Given this list of marker genes CNKSR2, TP53INP2, DLG1, RALGAPA1, SPIRE1, CLDND1, EIF4ENIF1, PKP4 (NCBI Gene Id 8502), RAN, DCUN1D4 (NCBI Gene Id 23142), UBE2H, WSB1, RABEP1 (NCBI Gene Id 9135), DNAJB14, TNS2, RABGEF1 (RAB guanine nucleotide exchange factor 1), ZNF536, ZEB2, UFSP2, POMT2, DIRAS1, ZER1, NOL6, BTBD3, GPRC5B, MGAT3, OCIAD1, MARF1, FBXO21 (NCBI Gene Id 23014), HERC2, PRXL2A, PTK2, FAM8A1, DYNC1I2, RASSF3, MEGF9, APPBP2, GLTP, CCDC88A, FNIP2, AGPAT4, ABHD6, WSB2, SLAIN1, BTRC (NCBI Gene Id 8945), STAMBP, PLEKHB1, MOAP1, EPB41L3, ABI2, NCS1, KIDINS220, NGRN, CCDC82, TJAP1, ANKS1B, ULK2, RNF13, ZNF710, FMNL2, ARPP19, WBP2, SNX27, SAP30L (NCBI Gene Id 79685), SHTN1, USP33, FAXDC2, KLHL21 (kelch like family member 21), GZF1, RTN4, PHYHIPL, TULP4, ANKRD17, ZFP14, NPTN, DYNC1LI2, GORASP1, CCDC92, TTL, TTYH2, TMOD2, BACE1, PREPL, ARHGAP21, ZNF84, LANCL1, RAPH1, PTPRD, MAPK8IP2, FADS1, BBS2, RABL2B (NCBI Gene Id 11158), TMEM184B, DZIP3, CLASP2, NAA30, KIF5C, TSNAX, DNAJC6, MYO10, USP32, YIPF5, DDHD2, SESN3, CIPC, GBA2, KIF1B, NAPG, GPR107, NIPA1, YWHAG (NCBI Gene Id 96443), AHCYL1, NDRG3, FAM168B, HERC4, MAP4K4, PPIG, TMEM30A, DOCK9, FAM219A, NLK, TRIM37, VPS52, SIK3, FRYL, ACTRT1, ZNF565, GOLGA7, LARGE1, PHLPP2, TAFA5, CLCN3, MAPK8IP3, MTMR2, C1orf198, PDP1, TRIM8, FBXW11, ARHGAP26, BLTP1, ATRN, PLEKHA1, TEX2, CAMK2G, PEG3, here is a description of the gene set: Neighborhood of PTK2 PTK2 protein tyrosine kinase 2 in the GCM expression compendium species: Homo sapiens Neighborhood of PTK2 Human Gene Set: GCM_PTK2